Given this list of marker genes Lgals3, Siglec1, Cd24a, Mir19b-1, Efna1, Blm, Cd274, Bcl2, Mir93, Ada, Il10, Ripk3, Mir363, Mir25, Bcl2a1a, Bcl11b, Fnip1, Mir20b, Bcl3 (B cell leukemia/lymphoma 3), Dock8, Hsh2d, Il2, Tnfrsf4 (NCBI Gene Id 22163), Prelid1, Noc2l, Cd44, Birc7, Aurkb, Cd3g, Slc46a2, Bax, P2rx7, Wnt5a, Rag1, Prkd2, Tnfsf4, Mir92-2, Casp8, Pdcd1, Cd27, Perp, Tgfb2, Rorc, Mir92-1, Mir106b, Vhl, Irs2, Kifap3, Pip (NCBI Gene Id 18716), Fcmr, Jak3, Pten, Ptcra, Foxp1, Nfkbid, Hif1a, Bmp4, Ccl5, Ido1, Lyn, Cd47, Arg2, Il7r, Serpinb9, Mir18b, Trp53, Zc3h8, Mir19b-2, Fadd, Tsc22d3, Pnp, Ormdl3, Cd74, Adam8, Prkcq, Pdcd7, Bcl2l11, Gpam, Slc39a10, Mif, Gimap8 (NCBI Gene Id 243374), Bbc3, St3gal1, Bcl10, Mir106a (microRNA 106a), Myc (myelocytomatosis oncogene), Il3, here is a description of the gene set: Mouse Gene Set: GOBP_REGULATION_OF_LYMPHOCYTE_APOPTOTIC_PROCESS Any process that modulates the occurrence or rate of lymphocyte death by apoptotic process. studied in species Mus musculus